The following is a description of a gene set: species: Homo sapiens Human Gene Set: GOBP_MESANGIAL_CELL_DEVELOPMENT The process whose specific outcome is the progression of a mesangial cell in the kidney over time, from its formation to the mature structure., and this is the list of marker genes: ACTA2, NOTCH1, PDGFB, OSR1, FOXC2, GPR4